Given this list of marker genes ZC3H12C, SLC4A7, PILRA, UBE2S, PLPP1, TNFAIP2, RTN2, TANK, CYRIA, CSRNP1, RNF31 (NCBI Gene Id 80191), TNFSF10, TRA2B, CALHM6, SC5D, CMPK2, PCGF5, TRIM13, MOB1B (MOB kinase activator 1B), ADM, PTPN11, USP18, STAP1, LARP1, DDX21, PLAGL2, FOXP4, SETDB2, RNF4, ENTR1, IKZF1, RNF14, OASL, HSD17B12, ACSL5, ECI2, ZBP1, ANKIB1, LTV1, CD14, REPS1, EHD1, TMBIM4, COQ10B, STX6, ADGRG6, SRC, MX1, NDEL1, SBDS, ADAR, PGS1, MVP, CSTF2, RSAD2, MED1, DENR, MX2, CACNB3, TMEM68, CP, HDC, TMEM176A, PLAAT3, MOCS1, PRKCD, XKR8, GNG12, NCF1, ZHX2, UBQLN1, JMJD6 (jumonji domain containing 6, arginine demethylase and lysine hydroxylase, NCBI Gene Id 23210), AMD1, ST3GAL1, ZNFX1, CLIC5, CDC42EP1, MAP2K1, AP3B1, OPA3, AGTRAP (NCBI Gene Id 57085), NOX1, TLR1, PSMB6, STX11, ZC3H12A, IL15, PTP4A3, LAYN, ITGA5, ISG20, SEMA4A, PARP12, NFKBIB, HERC5, TBC1D13, CD274, PROCR, RRAD, NOL10, DCUN1D3, PFKP, NCK1, RILPL2, SLC16A3, SLC16A10, KPNA3, HDLBP, TCOF1, TRIP10, TSC22D1 (TSC22 domain family member 1), PHF11, POFUT2, MOB3C, EBI3, EPSTI1, GPHN, TAGAP, SOCS3, SIAH2, ST3GAL3, SAR1A, RALGDS, ETF1, TMEM123, TMEM176B, RAB21, HBS1L, TENT4A, RBPMS, RCL1, ZUP1, GPBP1, STARD7, CHMP4B, CFLAR, IGSF6, LIMD1, SNX20, TRAM2, GLRX, DCAF12L1, KLF16, NOD2, FGL2, IFT57, GRAMD1A, IFIT2, LRRC8C, ZFAND5, BATF, EIF4E2, PSME1, EIF1, LCP2, RIPK2, SDE2, STIMATE, ARHGAP21, PSME2, SDC4, CXCL13, WTAP, SPRED1, PHTF2, CSDE1, PSMA6, PPP1R14B, TMEM38B, RAPGEF2, PFKL, ETV6, SLAMF1, ATP10A, TLNRD1, here is a description of the gene set: Genes down-regulated in endothelial cells: IFNG versus IFNG and B. burgdoferi. Human Gene Set: GSE6092_IFNG_VS_IFNG_AND_B_BURGDORFERI_INF_ENDOTHELIAL_CELL_DN Borrelia burgdorferi, the agent of Lyme disease, promotes pro-inflammatory changes in endothelium that lead to the recruitment of leukocytes. The host immune response to infection results in increased levels of IFN-gamma in the serum and lesions of Lyme disease patients that correlate with greater severity of disease. Therefore, the effect of IFN-gamma on the gene expression profile of primary human endothelial cells exposed to B. burgdorferi was determined. B. burgdorferi and IFN-gamma synergistically augmented the expression of genes, seven of which encode chemokines. Six of these (CCL7, CCL8, CX3CL1, CXCL9, CXCL10, and CXCL11) attract T lymphocytes, and one (CXCL2) is specific for neutrophils. Synergistic production of the attractants for T cells was confirmed at the protein level. IL-1beta, TNF-alpha, and LPS also cooperated with IFN-gamma to induce synergistic production of CXCL10 by endothelium, indicating that IFN-gamma potentiates inflammation in concert with a variety of mediators. An in vitro model of the blood vessel wall revealed that an increased number of human T lymphocytes traversed endothelium exposed to B. burgdorferi and IFN-gamma, as compared to unstimulated endothelial monolayers. In contrast, addition of IFN-gamma diminished the migration of neutrophils across B. burgdorferi-activated endothelium. IFN-gamma thus alters gene expression by endothelium exposed to B. burgdorferi in a manner that promotes recruitment of T cells and suppresses that of neutrophils. This modulation may facilitate the development of chronic inflammatory lesions in Lyme disease. from publication Dame TM, Orenzoff BL, Palmer LE, Furie MB (PMID 17202382) species: Homo sapiens